The following is a description of a gene set: species: Mus musculus Genes containing one or more binding sites for (Foxg1) in their promoter regions (TSS -1000,+100 bp) as identified by GTRD version 20.06 ChIP-seq harmonization. from publication Yevshin I, Sharipov R, Kolmykov S, Kondrakhin Y, Kolpakov F (PMID 30445619) Mouse Gene Set: FOXG1_TARGET_GENES, and this is the list of marker genes: Rbmx2-ps, Neb, Rgs8, Tceanc2, Parvaos, Nfkbil1, Fhad1, Ints1, Sart1, 5430400D12Rik, Mbd6, Runx2os2, Ndufs1, Babam1, Gm22571, Edrf1, Emx2os, Trib2, Sipa1l3, Slc12a6, Pgap1, Tmem127, Sfi1, Ibtk, Dnajc14, 1700055D18Rik, Dnajc6, Kcnip3, Ndufs8, Zfp945 (NCBI Gene Id 320457), Smpd3, Timm29, 4932412D23Rik, Nfix, As3mt, Nol4, Spty2d1, Trmt13, Sulf2, Gm34139, 1600023N17Rik, mt-Tv, Foxp4, Lcp1, Rufy3, A230028O05Rik (RIKEN cDNA A230028O05 gene, NCBI Gene Id 319487), Tpi1, Asap1, Myt1, Prkdc, Pnkd, Frg1, Abhd17a, Bahcc1, Gm13219, Thtpa, Gm9915, Trerf1, Nacc2, Wbp1, Traj27, Rfx2, Adipor2, Eef1b2, Ypel5, Socs1, Cnot1, Klhdc2, Slc35e4 (solute carrier family 35, member E4), Fbxo46, Kif20a, Hmbox1, Virma, Ube2a, Zfp608, Mcm7, D030047H15Rik, Kctd20, Derl3, Gm15423, Gm15938, Sass6, Prdm4, Max, Nek2, Abhd18, St18, Gm6517, 6430550D23Rik, Fosb, Cfap20, Enpp2, Ppp1r37, Dhx37, Slc5a6, Ncapd3, Bbs9, Desi1, Sema3a, Amfr, Epha7, Klf7, Usp31, Tnrc18, Agrn, Flywch1, Grhl2, Foxp1, Smg9, Tcp11l2, Rab18, Anxa4, Dach1, Steep1, Selenop, Bnip3l, Chmp5, Ubn2, Fdps (farnesyl diphosphate synthetase), Pag1, Atoh8, Dcun1d3 (defective in cullin neddylation 1 domain containing 3), Lemd1, Coa5, Igfbp4, Erlec1, Pdcd4, Tbx3 (T-box 3), Tcp11, Polr3b, Cblb, Zfp868, Mars1, Tctn3, Zcchc8, Cited2, Tyms, Rplp0, Gm826, 4930503O07Rik, Xpo7, Kdm6bos, Wdr90, Txndc2, Zcchc7, Mkrn3, Cds2, Setx, Dolpp1, Atg14, Nup88, 5530401A14Rik, Crebl2, Ccin, Nck2, Ubp1, Sult1d1, Vps26b, Ccng2, Pou2f1, Aamdc, Tmem94, Rpl27, Hif1an, Dph6, Btg1 (BTG anti-proliferation factor 1), Castor2, Pih1d1, Atg13, Wdr46, Klhl24, Ctns, Mynn, Pierce2, 2610307P16Rik, Katnip, Slc49a4, Ddx17, Smarcd3, Uhrf2, Ehmt1, Klhdc8a, Rcc1l, mt-Nd4, Pantr1, Ptpa, H2-T24, Gm11840, Marchf2, Optc, Slf1, Tnfaip8, Cage1, Fam131a, Mycn, Gtdc1, Zfp180, Gm6410, Per1, Wasf2, Baz2a, Slc38a10, Gm17501 (predicted gene, 17501), Atad3a, Arrb2 (arrestin, beta 2), Mrpl34, Ankrd55, Atxn3, Slu7, Id4 (NCBI Gene Id 15904), Gtpbp1, Dnajc12, Gm10244, Snora78, Siah3, Gm10222, Rps6kb2, Rsf1, 1700012C14Rik, Gm11872, mt-Tr, Hspbp1 (HSPA (heat shock 70kDa) binding protein, cytoplasmic cochaperone 1), Ing2, Mafk, 5830411K02Rik, Hs3st1, Por, Stxbp1, Slc35c2, Lrp8os2, Snx29, Psip1, Zc3h13, Ccl26, Ap4m1, Hapstr1, Gm10827, Asb3, Stag2, Rab5b, mt-Nd1, Gm11541, Rimbp2, Cbr4, Dpp9, Vps36, Slc36a4, Aamp, Klf13, Gtf2b, Akt2, 1700110K17Rik, Pik3c3, Mir6403, Fam181b, Pot1a, Gm13630, Slc4a2, Pdk4, Cyp2s1, Gm8307, B230354K17Rik, Nsa2, Shpk, Plekhm3, Mycl, Tef, 1700056E22Rik, Tbp, Mfsd6 (NCBI Gene Id 98682, major facilitator superfamily domain containing 6), Ngef, Hbp1, 1110002O04Rik, Tmem232, Myo1h, Stip1, Rsbn1l, Gm5432, Alg14, Htra2, Imp4, Otud1, Lingo2, Mrps25, Adi1, Zfp13, Cog3, Gm11655, Gm12973, Jtb, Gbp5, Hexim2, Fra10ac1, Mir7662, 2310001K24Rik, Anxa8 (NCBI Gene Id 218906), Tm9sf2, Hnf4a, Oser1, Vcf1, Mterf4, Dhx16, Mplkip, Nckap5, Zscan2, Sharpin, Gfra1, Pdk2, Bag1, Trim13, I830134H01Rik, 4930577N17Rik, Atg9b, Emx2, Mmut, Tex9, Dhx40, Gli2, Arhgap32, Alg8, 3300002A11Rik, Cdc5l, Slc15a4, Ccdc186, Lars2, Kcnn2, Nadk2, Ahcyl2, Rbm48, Trib1, Ppdpf, Gm3764, Smim3, Ubb, Rpf1, Gm16120, Bcas3, Bhlhe22, Gm28535, Ruvbl2, Gm5113, Gnpda2, Duxf1, Pafah1b3, Cdkn2d, Snhg5, Golgb1, Xrcc6, Bcorl1, Txnl4b, Sertad4, Wdr48, Snord53, Rgl1, Slc6a15, Peg3, Rcc2, Plekha3 (NCBI Gene Id 83435), Klhl18, A330093E20Rik, Rcan1, Ly6g2 (lymphocyte antigen 6 family member G2), Pcdh9, Wdr31, Cstf2t, Itpkc, Osbpl9, Macrod1, Nbr1, Slc25a28, Ece2, Adamts10, Phlpp1, Junos, Pknox2, Trp53inp1, Ergic3, Sgms1, Nlrc4, Pax6, Tfeb, Kiz, Mir3093, Hibadh, Tmbim6, Pdzrn4, Map2, Oga, Coil, Gm13580, D17H6S53E, Gpr180, Zfyve1, Jarid2, Gm13919, Rorc, Sox5, Hspbap1, Zswim4, Pura, Ankmy1, Mark2, Chd3, Gtf3c1, Atf7ip, Gabarapl2, Lsg1, Aacs, Acsbg1, Tnr, Rpl31, Hspa13, Usp29, Wdr45, Mir5627, Ypel4, 4930513N10Rik, Sugct, Arid4b (AT-rich interaction domain 4B), Wdr81, Tuba1a, Foxo3, Zic2, Mpv17, Ciao3, Adar, Tbc1d17, 2900052L18Rik, Tspyl1, Lpin1 (lipin 1), Ubxn1, Etv5, Zfp428, Neu2, Itgb1bp1, Ly6g6e, Mtor, Pcmtd2, Sfxn2 (NCBI Gene Id 98151), Rabgap1, Ubald1, Dhx38, Aup1, Neurog2, Txnip, Gsdmd, Snora64 (NCBI Gene Id 104366), Tnfrsf14, Ramac, Harbi1, Dnajc28, Cnrip1, Mcph1, Zkscan5, Mir670hg, Sox2ot, Gm37450, Dhx33, Abtb1, Cnnm3, Ap3s2, Slc29a1, Nt5c3, 4933407L21Rik, Spock3, Map2k6, Frat1, Ankrd40, Uggt2, Tnrc6b, Cenpf, Gm21985, Ephb6, Tst, Fam216a, Grk6, Ivd, Zfand2a, Ythdc1, Cbr1, Bbx, Ppox, Slc25a42, Asb1, Sptlc2, Rab23, Cdk5, Dcaf10, Rbm4b, Prr13, A930019D19Rik, Shld1, Gas1, Ric8a, Rmnd5a, Tlnrd1, Tecr, Crat, Bcl2l11, Cep55, Parvb, Gm23278, Mfap3, Ep300, Gm2449, Dennd2d, Atad3aos, Fbxl12os, Ctdsp1, Fitm2, Dnajc24, Abca1, Ing3, Slc35b1, Gm19412, Gar1, Herpud1, Wdtc1, Setd4 (NCBI Gene Id 93957), Cdk5rap2, Gas7, Wwc1, Tmcc1, Gucy1b2, Ubald2, Ciao1, Kif9, Ccni, Pdhb, Gm15441, Ankrd6, Nwd1, Clptm1 (cleft lip and palate associated transmembrane protein 1), Slc28a3, Tmem33, Pou3f3, Btc, Mapk3, Mkx, 9130024F11Rik, Septin7, AI854703, Wdr59, Acot10, Sh3kbp1, Hdac5, Klf4, Ndrg2, Vgll4, Ccpg1, Eef1g (eukaryotic translation elongation factor 1 gamma), Gm16537, Gfod1, Lrrc61, Med25, Mtmr14, Ogt, Gm26812, Bcl9, Chic2, Lrrc51, Dhx8, Lmo7, Lrrtm2, Tmem259, Poc5, Mir6236, Mir105, Dtx1, Rcc1, Gm25582, Kcnj15, Rbbp5, B4galt5, Zbtb6, Kti12, Tenm4, Stxbp6, Plcxd3, Il4ra, Zfp668, Ropn1l, Tmem71, 9430053O09Rik, Dusp4, Ghitm, Gcnt2, 3110070M22Rik, Akt1s1, Rere (NCBI Gene Id 68703), Tenm2, Ambra1, Cops6, Etv1, Meis1, Uqcc6, Sdcbp, Ighv1-67, Scarna2, Dusp10, Polr3k, Unc50, Osbpl2 (oxysterol binding protein-like 2), Rcan3, Rab5a, Lcp2, 9330159F19Rik, Tbc1d15, Map9, Apba3, Pold4, Ndufs2, Cic, Smim15, Ptprf, Tmem222, Ltn1, Papss1, Plekhm1, Zfp212, Gm9967, Maf1, Gadd45g, Gm49405, Yipf2, Mkrn1, Arhgap1, 2010109A12Rik, Prcc, Pax6os1, Mff, Gata3os, Lgals3, Rnf38, Mtnap1, Atraid, Alkbh5, D430040D24Rik, Zfp146, Cux2, Cul7, Zfp740, Sfr1, Atp6v1g2, Lfng, Mtf2, Dhx35, D830026I12Rik, Gm11399, Oas1g, Prpf31 (pre-mRNA processing factor 31), Ppp2r1b, Spry2, Dhx32, Top2b, Paxbp1, Tcf4, Mrpl39, Tmem101 (NCBI Gene Id 76547), Cfap68, Gpn3, Ntm, Sidt2, Sema3f, Pde1a, Alkbh8, Ppp1r7, Myh14, Atxn2l, Cops7b, Dlgap4, Dcaf8, Sec23ip (Sec23 interacting protein), Plxnd1, Zfp536, Ncapg, Fyco1, Taf4, Zfp772, Tpp2, Mir8101 (NCBI Gene Id 102465892), 9930014A18Rik, Yipf4 (Yip1 domain family, member 4), A330035P11Rik, Wdr5b, Gm12279, Insr, Lix1, Cep95, H4c16, Cacna1e, Nfia, Cox14, Otop3, Dusp6, Sdk1, Fam210a, Gm24246, Xpnpep3, Lin37, Mknk2, Slco2a1, Zfp874a, Tlx3, Pip5k1b, Cul4b, Uba6, Stc2, Tmem198b, Gm17764, Chd2, Tspan18, Kat6b, Eif3f, Csrp1 (cysteine and glycine-rich protein 1), Ccdc28a, Kdm5c, 5830418P13Rik, Snhg9, Ftl1, Ankrd10, Vamp8, 1810007C17Rik, Slitrk5, Gm26995, Cit, Bsdc1, Wbp2, Actn4, Mdga1, Tsc1, Zfp282, Pask, Fn3k, Fnbp1l, Rasgrp3, St13, Nr4a2, Plekha6, Snx15, Sde2, Dedd, Gm24154, Serinc1, Fam83e (NCBI Gene Id 73813), Polr2j, Runx1t1, mt-Tg, Thy1, Utp18, Rrp7a, Mpped2, Zbtb5, Tfpt, Bcar3, Ddx5, Dmxl1, Pfdn6, Ddr1, Ccndbp1, Tfap4, Aggf1, Eaf2, Gm15627, Tmem267, Mpst, Spag9, Lztfl1, Chchd5, Nkx2-2, mt-Nd4l (mitochondrially encoded NADH dehydrogenase 4L), 0610039K10Rik, Nr1h2, Mfsd8, 1700012J22Rik, Exoc7, Scg3, Gys1, Nrxn1, Mgat4c, Sephs2, mt-Rnr2, Gm20753, Vps51, Eola1, Cdadc1, Crbn, Gm15612, Tle4, Ints9, Mcm4 (NCBI Gene Id 17217), Rangap1, Tmem59, Atp6v1b1, Hmgb1, Tmco6 (transmembrane and coiled-coil domains 6), Plcg1, Abcb8, Tom1l2, Brd3, Ypel3, Ccdc117, Las1l, Gm13569, Ccdc115, 4930578M01Rik, Tbcel, R3hdm1, C9orf72, mt-Nd3, Adpgk, Gm28209, Kcnu1, Tacc2, 1110025M09Rik, Hmgn2-ps, Leng8, Cilk1, Mef2d, Mir7238, Gbp7, Bbc3, Vkorc1, Syf2, Pex1, Mir9-1, Zranb3, Iscu, Spdef, Heph, Gm5335, Lrrc24, Ccz1, Gm8357, Fhit, 9630028B13Rik, Dnajb12, Akap9, Zfp622, Itgb6, Pi4k2a, Ube4a, Fam53c, Akr1b1, Dynlrb2, Atosa, Gm15564, Rap2a, Gm5370, Cfap276, Gfm2, Zer1, Usp9x, Fadd, Mxd4, Zfp113, Bmp8a, Bet1l, Zbtb26, Actl11, Abr, Cpsf3, G630016G05Rik, Cyp2d26, Or6c202, Fbxo9, Crtc2, Ifit2, Frat2, Zfp874b, E130006D01Rik, Rps21, Cmtr1, Pxk, Fzd7, Ppp1r15a, Gm14053, Hinfp, Adgrl2, Cox20, Thg1l (NCBI Gene Id 73621), Zfp788, Cbll1, D2hgdh, Atxn7l1, Ube2b, Lsm14b, Oas1a, Maml3, Peli1, Kdm6a, Zfp646, Rps6ka5, Iba57, Prr15l, Rgs3, Slc25a36, 1700040F17Rik, Rbm39, Tbrg4, Dusp23, 1700029J03Rik, Palmd, Paip2b, Slc29a4, Rnmt, Peli2, Fbxl20, H3c6, Frmd5, Smg6, Rpain, C230014O12Rik, Pdxdc1, Drc3, Gm22936, Acbd5, Car11, Stk40, Mbtd1, Sebox, Elavl2, Dnajb9, Mir707, Lockd, Creb5, Atp6v0e (ATPase, H+ transporting, lysosomal V0 subunit E), Meis2, Mlip, Grcc10, A430033K04Rik, Plcl1, Gm22858, G3bp2, Sphk1, Camta1, Elavl4, Mturn, Bmal1, Dcdc5, Anks1b, mt-Tl1, Ypel2, Phf3, Zfp408, Aicda, Bicc1, Junb, H4c14, Gm9929, Hnrnpr (heterogeneous nuclear ribonucleoprotein R), Rhebl1, Rpp14, Prkce, Rps2, Srl, Ireb2, Calcoco1, Actb, Lmna, Magi1, Xbp1, Zbtb40, Zfp280b, Nub1, Slc25a26, Ctsd, Ddx24, Neurod6, Ttc33, Cfap251, Foxp2, Vps13b, Trp53rka, E130102H24Rik, Mgat4b, Arap2, Npsr1, Pik3ca, Arhgap11a, Pik3ip1, Ggps1, Mir99ahg, Frem1, Hsf2bp, Mir701, Efna1, Nfatc2, Xpnpep1, H2az2, Edil3 (EGF-like repeats and discoidin I-like domains 3), Rps5 (ribosomal protein S5), Mrpl1, Pank1, Sbf2, Klf6, Tfdp2, Brca1, Rxfp2, Arhgef1, Fdxacb1, Ncstn, Palld, Mir3091, Sdcbp2, Smad6, Spata31e2, Ficd, 2810013P06Rik, Bach2it1, Nmb, Ocrl, Parn, Bod1l, Entpd1, Atf6, Ndufs4, Tbc1d23, Tpk1, Sgf29, Dusp26